Given this list of marker genes Aplp2, Dnajc13, Grk1, Cldn11, Abr, Pou2f3, Kdm5c, Kif21b, Acot11, Acox1, Onecut2, Syndig1, Atp2a3, Dram1, Smad7, Cnr2, Pycr1, Pou2f1, Evl, Plec, Rtn4ip1, Trim66, Prr3, Hoxb6, Lrrc55, Tnrc6b, Fam53b, Nhsl2, Abcc3, Tgfb3, Syn1, Kdr, Ube2q1, Smc1a, Ak2, Cerk, Pip5k1a, Fndc5, Ccdc191, Acnat1, Tbx20, Zfp541, Baiap3, Dlx3, Aak1, Cnnm4, Atp6v1g3, Asb13, Prkcq, Zfp609, Clvs2, Ikbkb, Pkdcc, Slc31a2, Slc23a2, Mtcl2, Atosa, Sema5a, Prr14l, Ttn, Map6, Akap8 (A kinase anchor protein 8), Aacs, Hars2, Cd300e, Socs7, Pla2g2f, Kcnn3, Manf, Srf, Tmco5b, Cdk9 (cyclin dependent kinase 9), Mllt6, Stk35, Prss8, Bcam, Bgn, Smpdl3b, Gigyf2, Jph1, Hoxb5, Tub, Ark2n, Morc2a, Sertm1, Eno2, Fancm, Ncam1, Micall1, Tmem260, Mtmr4, Dnm1, Tmed3, Paxip1, Slc6a7, Tbl1xr1, Mpzl1, Frrs1l, Txnl1, Apbb2, Chkb, Sntb2, Mettl25b, Slc6a3 (solute carrier family 6 (neurotransmitter transporter, dopamine), member 3), Lmnb2, Trim8, Mas1, Tmem220, Xpo7, Cyth3, Med22, Dennd11, Chst3, here is a description of the gene set: Mouse Gene Set: MIR_665_3P studied in species Mus musculus Genes predicted to be targets of miRBase v22 microRNA mmu_miR_665_3p in miRDB v6.0 with MirTarget v4 prediction scores > 80 (high confidence targets). from publication Chen Y, Wang X (PMID 31504780)